The following is a description of a gene set: Genes down-regulated in visceral adipose tissue of aged mice: T reg versus T conv. We identified Pparg as a major orchestrator of the phenotype of adipose-tissue resident regulatory T cells (VAT Tregs). To establish the role of Pparg in shaping the VAT Tregs gene profile and cell dynamics, Tregs from lymph nodes and visceral adipose tissue of mice sufficient and deficient of Pparg expression in Tregs were double sorted for microarray analysis. from publication Cipolletta D, Feuerer M, Li A, Kamei N, Lee J, Shoelson SE, Benoist C, Mathis D (PMID 22722857) studied in species Homo sapiens Human Gene Set: GSE37532_TREG_VS_TCONV_CD4_TCELL_FROM_VISCERAL_ADIPOSE_TISSUE_DN, and this is the list of marker genes: LAPTM5, AQP12A, CRELD2, HMMR, SPCS2, HPGDS, SMC1A, ALMS1, BTBD1, OSBPL2, RRM2B, ARL5A, ANLN, CTNS, KDM4A, JKAMP, MCOLN3, GOLGA7, BDH1, PDP2 (NCBI Gene Id 57546), SSR3, ERH, PAICS, TMPO, SUMO1, NEK9, LRRC1, ZCCHC24, NHLRC3, BUB1B, ALG5, RDH12, TGDS, SELENOF, NUP205, PRIM1, GDI2, LIG1, GNPDA2, ANKRD6, SPECC1L, ILF3, P4HB, NUP37, ACOT13 (acyl-CoA thioesterase 13), STAT3, ZFP62, CASP1, UTP14A, KARS1, CD46, RTP4, POLE4, IFNAR2, MARCHF6 (membrane associated ring-CH-type finger 6), IKZF5, KIF4A, RAD9B, CALM1, ATP6V1A, EIF4B, GOSR2, PBK (NCBI Gene Id 55886), CFLAR, INTS12 (NCBI Gene Id 57117), CEP68, UBE2L3, ATP5PB, NCAPG, PALLD, MXI1, THOC7, AGA, NAF1, PPM1L, RRM1, MOB1A, NDE1, SSBP3, COPS2, MSL3, RIOK1, NONO, GNAI3, TEX101, TMEM106B, THAP12, ARF4, RAD51, RIGI, SMIM11, PLEKHF2, CAPN7, NKAPD1, UBE2N, EIF2A, LMOD2, ZCCHC17, TMEM183A, EIF3E, BET1, ZBTB33, RFC3, ZDHHC2, ADI1, SYNRG, PA2G4, MDM2, EIF1AD, AP1S3, RNF213, SLC44A1, CDC42, MAPKAPK5, ACADL, STRAP, STIL, SLBP, NUFIP1, NPC2, BANK1, XIST, DLGAP5, GLIPR2, MTCH2, TFAM, TOP2A, TMOD3, AK2, FICD, PSMC4, TRIM59, MRPL32, LY75, MT-ND3, CGRRF1, OLFM4, SLC25A32, HYLS1, TSHZ1, ARHGAP11A, FUCA2, MAD2L1, SLC25A51, P4HA1, EIF3J, HDAC2, POLR2D, PWWP3B, CCNI, SPTY2D1, TRAT1, ME1, NAA38, TLR7, GNS, HEBP1, TBCA, IPO9, FAM32A (family with sequence similarity 32 member A), QRSL1, TTC32, COMMD10, BPNT2, RUVBL1, NES, ANP32B, INCENP, KIF11